Given this list of marker genes MGST1, CAV1, HBEGF, PLAUR, SPRY1, PTGS2, CD44, STMN1, MMP10, VIM, FLNC, SPP1, MVD, IL1RL1, BCL3, LBH, CA3, here is a description of the gene set: species: Mus musculus from publication Matthews CP, Birkholz AM, Baker AR, Perella CM, Beck GR Jr, Young MR, Colburn NH (PMID 17363560) Human Gene Set: MATTHEWS_AP1_TARGETS Known targets of AP1 that were down-regulated by overexpression of TAM67, a dominant-negative form of JUN. Activation of activator protein 1 (AP-1) and nuclear factor kappaB (NFkappaB)-dependent transcription is required for tumor promotion in cell culture models and transgenic mice. Dominant-negative c-Jun (TAM67) blocks AP-1 activation by dimerizing with Jun or Fos family proteins and blocks NFkappaB activation by interacting with NFkappaB p65. Two-stage skin carcinogenesis experiments in a model relevant to human cancer risk, transgenic mice expressing human papillomavirus 16 E7 oncogene (K14-HPV16-E7), show E7-enhanced tumor promotion. A cross to K14-TAM67-expressing mice results in dramatic inhibition of tumor promoter-induced AP-1 luciferase reporter activation and papillomagenesis. Epithelial specific TAM67 expression inhibits tumorigenesis without affecting TPA- or E7-induced hyperproliferation of the skin. Thus, the mouse model enriches for TAM67 targets relevant to tumorigenesis rather than to general cell proliferation or hyperplasia, implicating a subset of AP-1- and/or NFkappaB-dependent genes. The aim of the present study was to identify target genes responsible for TAM67 inhibition of DMBA-TPA-induced tumorigenesis. Microarray expression analysis of epidermal tissues revealed small sets of genes in which expression is both up-regulated by tumor promoter and down-regulated by TAM67. Among these, cyclooxygenase-2 (Cox-2/Ptgs2) and osteopontin (Opn/Spp1) are known to be functionally significant in driving carcinogenesis. Results identify both Cox-2 and Opn as transcriptional targets of TAM67 with CRE, but not NFkappaB sites important in the Cox-2 promoter and an AP-1 site important in the Opn promoter.